The following is a description of a gene set: A protein deubiquitination process in which a K63-linked ubiquitin chain, i.e. a polymer of ubiquitin formed by linkages between lysine residues at position 63 of the ubiquitin monomers, is removed from a protein. species: Mus musculus Mouse Gene Set: GOBP_PROTEIN_K63_LINKED_DEUBIQUITINATION, and this is the list of marker genes: Usp20, Nop53, Brcc3, Abraxas2, Psmd14, Stambpl1, Zranb1, Usp9x, Cyld, Brcc3dc, Otud4, Otud5, Vcp, Usp25, Yod1, Usp13, Tnfaip3, Otud1, Atxn3, Otub2, Usp27x, Usp8, Usp17le, Spata2, Stambp, Shmt2, Usp33, Otud7b